Given this list of marker genes Tgfb2, Hif1a, Smad3, Smad4, Wnt11, Bmpr1a, Gata6, Atf2, here is a description of the gene set: The appearance of transforming growth factor-beta2 due to biosynthesis or secretion following a cellular stimulus, resulting in an increase in its intracellular or extracellular levels. species: Mus musculus Mouse Gene Set: GOBP_TRANSFORMING_GROWTH_FACTOR_BETA2_PRODUCTION